Given this list of marker genes Gorasp1, Tgfa, Sec16b, Dctn6, Tuba8, Tuba4a, Sec24d, Arfgap2, Tmed10, Kdelr3, Tubb4b, Sec24a, Trappc9, Sec31a, Ank1, Folr1, Lman1, Bet1, Cog7, Tubb4a, Dctn1, Tubb2b, Rab1b, Sec24b, Copb1, Sptbn4, Arcn1, Sec31b, Actr1a, Tuba1c, Scfd1, Dynll1, Lman1l, Tmed3, Kdelr1, Copb2, Copg1, Ppp6c, Cog8, Tubb6, Arf5, Tuba1a, Sptbn2, Actr10, Tubal3, Kdelr2, Uso1, Tmed9, Ctsc, Cnih2, Ins1, Ins2, Tuba3b (NCBI Gene Id 22147), Golga2, Col7a1, Cd55, F8, Trappc5, Arf1, Lman2l, Dync1li2, Areg (amphiregulin), Copg2, Tuba1b, Nsf, Rab1a, Cnih3, here is a description of the gene set: Reactome Pathway: ER to Golgi Anterograde Transport part of: Membrane Trafficking; Transport to the Golgi and subsequent modification This event has been computationally inferred from an event that has been demonstrated in another species.<p>The inference is based on the homology mapping from PANTHER. Briefly, reactions for which all involved PhysicalEntities (in input, output and catalyst) have a mapped orthologue/paralogue (for complexes at least 75% of components must have a mapping) are inferred to the other species. studied in species Mus musculus electronically inferred by orthology from the curated human pathway